The following is a description of a gene set: Mouse Gene Set: REACTOME_RESOLUTION_OF_ABASIC_SITES_AP_SITES species: Mus musculus Resolution of Abasic Sites (AP sites), and this is the list of marker genes: Rfc5, Lig3, Polb, Neil1, Fen1, Parp1, Pole, Smug1, Pold2, Neil2, Pnkp, Pcna, Parp2, Rpa3, Rpa2, Rfc2, Rpa1, Parg, Xrcc1, Mpg, Pold3, Mutyh, Mbd4, Nthl1, Lig1, Pole3, Rfc3, Ung, Rfc4, Tdg, Adprs, Pole2, Ogg1, Pole4, Pold1, Apex1, Rfc1, Pold4